Given this list of marker genes Pi4k2b, Mtmr4, Pi4k2a, Mtmr2, Inpp4a, Inpp4b, Pik3r4, Pik3c3, Inpp5f, Mtmr12, Mtm1, Fig4, Pik3c2a, Pikfyve, Vac14, here is a description of the gene set: species: Mus musculus Synthesis of PIPs at the early endosome membrane Mouse Gene Set: REACTOME_SYNTHESIS_OF_PIPS_AT_THE_EARLY_ENDOSOME_MEMBRANE